Given this list of marker genes HINT1, SENP1, SENP6, DESI1, USPL1, SENP5, SENP7, SENP3, SENP2, here is a description of the gene set: species: Homo sapiens Human Gene Set: GOBP_PROTEIN_DESUMOYLATION The process in which a SUMO protein (small ubiquitin-related modifier) is cleaved from its target protein.